The following is a description of a gene set: Pointed chin Human Gene Set: HP_POINTED_CHIN species: Homo sapiens A marked tapering of the lower face to the chin., and this is the list of marker genes: PRKG2, CLIP2, MED12L, CHD8, KDM3B, PLK4, PRKCZ, TBC1D7, DNM1L, PLOD3 (NCBI Gene Id 8985), NCF1, TTC5, SCUBE3, ANKRD11, NOTCH2, GTF2I, PIGU, MYH3, GJA8, UBE4B, SNX14, PUS7, FBXO11, CDK10, HSPG2, CBFB, LIMK1, STX1A, FGF3, DNAJC30, PDGFRB, KAT6A, CDH11, CAMTA1 (NCBI Gene Id 23261), TUBGCP6, SPEN, PSMB10, ELN, NGLY1 (N-glycanase 1), KIF11, CUL7, AP4E1, ZFX, METTL27, LUZP1, JARID2, FKBP6, COL2A1, MADD, NR2F1, THOC6, SPTBN1, SPRED2, PRDM16, DHX37, GABRD, POLR3A, MMP23B, RALA, POC1A, PDCD6IP, TLK2, PIGB, LZTR1, TBL2, CHRNG (cholinergic receptor nicotinic gamma subunit), CHD1, RFC2, PUM1, SLC37A4, CRELD1, MRAS (muscle RAS oncogene homolog), POU4F1, ZNF148, MAPK1, DOCK3, HRAS, ACTG1 (NCBI Gene Id 71), SET, OTUD5, CCDC8, CASZ1, SKI, RMRP, ATP6V1E1, GTF2IRD1, INSR, SIN3A, UGDH, BICRA, NSD1, RERE, CHAMP1, KCNAB2, MEIS2, CRKL, OBSL1, PORCN, ZNF292, TMEM270 (transmembrane protein 270), TRIP12, MAN1B1, ACTB, ZEB2, EIF4H, KIFBP, NFIX, FGD1, FN1, PGM2L1, ASCC3, FLNA, BAZ1B, CTCF, PDPN, TAFAZZIN, YY1, CDH2, SPOP, BUD23, SETD2, ERI1, TUBGCP4, HS2ST1, MESD, GJA5, POGZ, FRA10AC1, MAP3K7, CLCN4, ZNF526 (NCBI Gene Id 116115), LMNB1, ABL1, SETBP1, VPS37D, GTF2IRD2, TAF1, SHANK3, BCR, TMEM94